The following is a description of a gene set: Genes containing one or more binding sites for (ZNF318) in their promoter regions (TSS -1000,+100 bp) as identified by GTRD version 20.06 ChIP-seq harmonization. Human Gene Set: ZNF318_TARGET_GENES from publication Yevshin I, Sharipov R, Kolmykov S, Kondrakhin Y, Kolpakov F (PMID 30445619) studied in species Homo sapiens, and this is the list of marker genes: TNFAIP8L1, MLH1, COG4, TXN, MX1, VAT1, GYPA, IRF2-DT, CAND1, TAP1, SEC13, TVP23B, MIR194-1, SIRT4, ANKRD24, EP400P1, STON2, DTX3, RPL15 (ribosomal protein L15), BTBD19, NRSN2-AS1, SEL1L3, APOOL, DUTP1, MAT2B (methionine adenosyltransferase 2 non-catalytic beta subunit), RPL7, DDX42, CTTN, FEM1A (fem-1 homolog A), RPS10, RNU2-2P, RPL4, ZNF280B, NOS3, USP36, ZNF432 (zinc finger protein 432), RNY3P11, APOL1, IQCG, MORF4L2, PLIN3, VWA8, CTNNA2, VMP1, ZBTB38, TFRC, LINC00649, ADARB1, NR1D2, AP1G1, ATP8A1-DT, RPL32, ENTPD6, EIF4G3, MIR3677HG, SNORD43, TNFRSF19 (TNF receptor superfamily member 19), ZFAND3, LARP1, TMEM116, LINC02608 (long intergenic non-protein coding RNA 2608), RPL36, FAM13A (family with sequence similarity 13 member A), PXN, PAQR3, SELENOKP2 (NCBI Gene Id 100127908), RNVU1-31, RFX5, GYPE, USP9X, NDUFA4L2, KCNH8, ENSG00000266401, KRTAP2-4, LINC03023, YPEL3, PSAP, NFKBIL1, SLC51A, CDK16, EPS15L1, ATF6-DT, SIX5, RNVU1-18, ENSG00000268129, ACOX2, RNU12, RNVU1-3, NOL8, HPS6, RFX2, THAP9, HMBS, KLHDC8B, LINC02953, RNU1-108P, TMEM259, PEX1, RPL7L1, LINC00299, RIMOC1, MTATP8P1, HNRNPUL1, ISY1, MTFR1L, LGALS1 (galectin 1), CYTOR, ATP8A2, BHLHE40-AS1, RPS3, ERP29, NBN, SLC35E2A, YWHAE, CP, APOBEC3C, ENSG00000255491, SNORD15A, GNL3L, LINC01275, GARNL3, RPL23AP81, PUM1, SNORA50C, ESAM, SNORD58A, LONRF1, EIF2S3, RPL17, SNORD118, ZSWIM8, CCDC150, EVL, PLAU, PPP1R9B, TNK2-AS1, RESF1, GBA1, ISG15, MDGA1, SMAP2, MRPS18B, HID1, GTF2A1-AS1 (GTF2A1 antisense RNA 1), TMEM144, DIPK1A, RPL26, LINC01132, RBM48, HEMK1, SKIDA1, ENSG00000246308, ACSM3, UBE2O, ERAP1, SAE1, CCDC42, MBD5, HES1, LCORL, LRBA, EEIG2, RNVU1-30, FOSB, CREB3L1, RNU2-17P, LINC00964, PCAT6, RBL1, ZCCHC24, SCARB1, TPP1, TRAPPC9, SYNGAP1, ADGRG3, APOL3, UBE2Q2P13 (NCBI Gene Id 100128108), CDK11B, BCL3, FRAT1, SEC31A, POLB, OSGIN1, RPL37A, TEPSIN, POLR2J3, RPS9, ALAS1, ISLR2, ALG1L13P, FABP5P5, SSBP2, GREB1, ENSG00000259118, C7orf50, LINC00944, RNVU1-28, HJURP, ERC1, RALGDS, GCDH, DZIP1L, ZDHHC20-IT1, ABHD12, LTBP1, SAMD4A, SPATA1, SRP72, GUSB, GOLGA3, TRIB3 (tribbles pseudokinase 3), RNU7-1, PNPLA1, TACC3, PARP14, RHOBTB3, ABCG1, NRG4, FOSL2, RPL7A, YBX3, CDA, AFG2B, GBE1, GDF11, CLIC4, PCID2, MYL6B-AS1, APOLD1, FAM83A, ZFPM2-AS1 (NCBI Gene Id 102723356), SCUBE1-AS1, C9orf72, SMG7, TM2D3, WDR36, SMG1P1, DAXX, WDR74, GDF15, DM1-AS, BRD7, SEC24C, STRIP1, FAM111A, ZFR2, ACIN1, FAM83G, TSR2, KAZN, ATF4, CCNG1, ENSG00000187951, MED22, IQGAP2, ENSG00000267174, NAT10, GABPB2, LAMTOR1, ZC3H7A, RNU2-63P, MRPL48, GTPBP2, FXYD2, TRIP6, TCAM1P, SLC6A6, SOCS1, CREM, IRF2, ATP1B3, RN7SKP91, SMARCA2, CDCA7, DSCR8, NFIX, TIMM17A, CASS4 (NCBI Gene Id 57091), HDAC6, DPH5-DT, CRPPA-AS1, RNVU1-27, LYN, CMSS1, RNVU1-2A, ST13, TPM4, FOXK2, SLC25A10, ANAPC10, IFI6, CD70, UBE2I, GET3, ERMARD, ANKRD1, SSC5D, RGS20, DSCR4, CCDC8, S100A2, TTC39A, TMEM18, AMOTL1, MED8, RAB7A, XXYLT1-AS2, TMSB4X, ENSG00000249713, LNCTSI, LINS1, PRELID1, SLC41A2, H4C8, AP2B1, WWC2-AS1, MOK, RAD52, MYH9, FCHO1, ZBED5-AS1, ID2, PSMB8, SLC26A8, ZNF335, ODC1, CDYL, TMBIM1, CRTAP, STAG2-AS1, LINC01300, STK40, ABCE1, NFIA, DNASE1L3, CEBPB-AS1, GABARAP, TRAJ7, CASC3, WRNIP1, OSER1, MEF2C, SNX29P2, H2AC6, TRIM2, TCF3, PLEKHA4, AHI1, TBL1X, FBXL9P, SNORD13, ATAD2, LNC-LBCS, THUMPD3-AS1, GRK2, ANXA11, MYEOV, ZNF138, TRIM25, RNVU1-34, DUSP16, RPL5, MYO18B, TUBB2A, COPZ1, GATAD2A, SP110, BHLHE40, FAM21FP, BRCA2, TFE3, BZW2, GNL1, RPS15, RNVU1-25, DNAJB2, RN7SKP168, PEAK1, CENPW, FCRLB, SLC7A8, ENSG00000253986, SLC13A3, BSG, PLA2G6, DUSP10, HOXC13, MAST2, NUP155, CCDC47, RPL37A-DT, RNU4-1, WDR76, ANXA2, MAF, IGF2BP3, MSLNL, PPP1R13L, PRR3, SYF2, RPL29P20, LINC01531, DHRS3, GLA, RPL36P10, DLX4, ANKUB1 (ankyrin repeat and ubiquitin domain containing 1), S100PBP, B3GNT8, IKBKG, CCN1, RPS18, SCFD2, PARP12, BRD2, NAPEPLD, USP49, CTH, MPV17, GP6-AS1, LINC02777, PABIR1, DDX39A, KIAA0319L, WDR45, RASA4CP, GCLM, SNRPE, FUT3, QPCTL, DDX39B, RPL38, ST7-AS1, ANKRD53, MED6, VIM, RNVU1-4, IL1R1, ZDHHC17, CCNG2, DNHD1, FAM184A (family with sequence similarity 184 member A), NCSTN, OSBP, SLC22A18, NSUN6, SNORA7A, THAP4, ZNF574, RPL35, LINC02980 (NCBI Gene Id 124906555), RPL23, AIG1, STAG2, RPS14, CTCFL, EHD1, ARHGAP1, ADAMTS6, LINC02652, KIF2A, KNL1 (kinetochore scaffold 1), EEF1A1, RPL29, RPL41, S100Z (S100 calcium binding protein Z), B3GAT3, ODC1-DT, PTCH1, SUGP2, PCBP1-AS1 (PCBP1 antisense RNA 1), KDM5C, MIR4757, RUFY3, JMJD1C, POLDIP3, C6orf52, BCAT1, SBNO2, ATP8A1, LINC01679, NMI, PPP1R15A, ATP2C1, RN7SL36P, FAH, RUNX1T1, RNVU1-21 (NCBI Gene Id 106480190), SETD7, HDDC2, SLC3A2, DEDD2, RBM3, GPI, KIAA0586, ATP6V1G2-DDX39B, CENPT, HNRNPH2, NIPA2, RERE, LINC00938, WDR1, ZFR, SREBF2, NR4A3, ENSG00000237813, MIR22HG, EIF6, PLCB1, HOMER1, DCTN6, MAU2, DDIT4, RPS3A, GCSAML, ITGB5, CD59, ABCC3, NDUFS3, CHMP3, CLCN3, SLC12A8, ZNF561, ATF7IP, GFI1B, MPDU1, YWHAQ, TUBGCP3, ING5, ISY1-RAB43, CASP8, CEP85, FTL, PCBP2, AXL, LINC01748, NFKBID, NKIRAS1, APOL2, COTL1, AKNAD1, NR4A1, LINC00887 (NCBI Gene Id 254808), RNA5S17, RNVU1-7, ENSG00000258623, ARAP3, FLT3LG, CFAP96, RHOT1, LINC00607, FAXDC2, POLR1G, ENSG00000235480, RPS24, ST7-OT4 (NCBI Gene Id 338069), PAXBP1, ALDH1A2, ZBTB21, ABHD2, BOLA2P1, PATL2, ZNF451, H4C4, WASHC2A, SEC22B, MTATP6P1, PPP4R1L, LINC00958, ARG2, FAM118A, MUS81, ZFAND3-DT, NFKBIE, GHRL, PCYOX1L, AVL9, MIR3189, MORF4L1, SLC48A1, WDR62, MORF4L2-AS1, CFAP20, FAM53C, AMMECR1L, THADA, RNU5A-1, FAM241B, CD163L1, TGIF1, ZNF561-AS1 (ZNF561 antisense RNA 1 (head to head)), RFX5-AS1, LINC00957, RNU5E-6P, COPA, SNORA21, SIAH1, LINC01719, LINC02100, TNFAIP3, ZEB2-AS1, RCOR1, TAGLN2, SPTA1, ADAR (adenosine deaminase RNA specific), GNGT1, IDS, SERTAD4, SP140L, DMWD, MIR5188, ENSG00000273727 (U1 spliceosomal RNA), CHD2, NKD2, TMEM132A, ABT1, POPDC2, ZNF841, BCL2, TNFRSF10B, TRIM11, OGT, UBC, LAPTM4B, PRR7, ADSS1, RPL17-C18orf32, ISG20 (NCBI Gene Id 3669), ADO, ITPR1, SNORD68, HJV, HTATSF1P2, ST7 (suppression of tumorigenicity 7), LGI4, ALKBH3-AS1 (NCBI Gene Id 100507300, ALKBH3 antisense RNA 1), TTI2, PARP10, LINC01366, ENSG00000189229, ZRANB2-DT, G6PC3, RPL10A, RPSAP28, CUX1, LAMP1, RNU5E-1, DMXL2, RNU5D-1, PDXK, VPS52, SHISA5, FAM186A, ZC3H4, KRT18, KLRK1-AS1, TSC1, KAT2B, EIF4ENIF1, FBXO8, ATP6V1G2, ZAR1L, SLC4A1AP, PLAAT5, RN7SL473P, ZNF669, STAT2, KDM3A, SLEAR, OSER1-DT, STAT1, NKIRAS2, BPHL, CYTH1 (NCBI Gene Id 9267), KICS2, ASIC4, IGFL2-AS1, RNVU1-26, POLR2M, ENSG00000227706, MSRB1, YARS1, ALDH5A1, CD164, CHPT1, TNS1, INO80, CLASP2, HIVEP3, RNVU1-15, NSMAF, REXO4, MPDU1-AS1, APOBEC3D, THAP8, DDX39B-AS1, MYL4, TRIM69, MTHFR, PTBP1, FHDC1, EIF2AK3-DT, MRPL1, PRDM10, BAIAP2, SARDH, ATF3, MBD6, ARL5B (ADP ribosylation factor like GTPase 5B), CLCN6, PPM1K, VPS54, ENSG00000268460, FLJ12825, C12orf57, MCL1, CD63, SUCLA2, ANP32E, SSR4P1, RNU6-2, ILF3, UNKL, DYNLT4, ZBED5, MED15, RNU4ATAC, LURAP1L-AS1, HMGB3P32, VAMP2, SPINK4, ILF3-DT, NAGLU, NRSN2, MIDN, RPL6, CSF2RA, NR2F6, RPL34, ARPC5L, ZNF292, BTN2A2, SNORD95, DDX18, PI16, PPP3CA, GADD45B, ZNF131, SF3B3, PPP1R10, RPS2P6 (NCBI Gene Id 342808), SZT2, RPS15A, DEDD (NCBI Gene Id 9191), FOXA1, KDM1B, MAGOHB, PATL1, TBC1D4, CHCHD2P1, SRRT, NUCB2, DYNLL2, LINC02000, RPAP1, MIR4435-1, SREBF1, CD27-AS1, RELN, TBC1D16, MIRLET7IHG, CLPTM1, CASK, ABCA15P, FBN3, GARRE1, MFAP4, TMEM208, TSC22D4, FBXL13, B2M (beta-2-microglobulin), TDH, SMARCE1, LINC01287, CYP1B1-AS1, ANKRD11 (ankyrin repeat domain containing 11), TM9SF4, NCDN, MIOS-DT, KNTC1, CREB5, TIMM9, GOLGB1, RNU7-124P, PPM1K-DT, SRSF3, MAN2A2 (NCBI Gene Id 55485), LSM5, MYB, CSRNP1, RNVU1-29, TMEM248, GYPB, FBXO45 (NCBI Gene Id 414772), NEDD4L, NHLRC2, ELSPBP1, DMAC2L, BCKDK, ACBD5, DPY19L3, PDE6G, FBLN2, MIDEAS, THAP9-AS1, TBC1D13, PRMT1, SNORD58B, LINC01418, SORBS1 (sorbin and SH3 domain containing 1), RENBP, ENO3, SLC45A4, USF2, GRPEL2-AS1, NFKB1, INO80C, ANAPC5, PAK1IP1, LINC00656, DYNLL2-DT, ENSG00000266976, SLC39A8, RNU5F-1, ADGRE5, HES4, TM4SF19-DYNLT2B, PIP4P1, RPL27, TENT5B, SEPTIN6, ZNF275, CMTM3, RPL37, DNAJC7 (DnaJ heat shock protein family (Hsp40) member C7), KLHDC9, BIN1, MEIS2, BAGE2, SLC9A1 (NCBI Gene Id 6548), EIF4E, TRPV2, ZNF408, RMC1, ITM2C, TRAPPC14, RPL11, RNU5E-4P, LEMD2, SNORD3J, DDX3X, ELOVL6, SUPT7L, GNLY, CLIC2 (chloride intracellular channel 2), SPRED2, MIR5087, PICALM, SOCS2, RRN3P3, TBC1D25, RSRC2, LINC02139, CTNND1, PRSS16, AKR1A1, BSG-AS1 (BSG antisense RNA 1), BCL6, RIMBP3, LINC01258, RPL34-DT, ATF6, KIF5C (kinesin family member 5C), LINC00475, SCIN, EIF4G2, LINC01610, RN7SL371P, RPL9, INHA, MAFK, MAP3K7, RSAD2, ABCB9, OTUD5, TNPO2, HSP90AB1, NEB, DUSP13B (dual specificity phosphatase 13B), PABIR3, LINC02870, PRECSIT, YTHDF2, LINC01270, SFT2D3, KLF6, TAPBPL, GNG5, OBSL1, CNOT6, CYTH4, ZDHHC6, NEAT1, KAT6B, IRF2BP2, SEPTIN8, NSUN4, DPY19L3-DT, PDE4A, NUB1, CHTOP, HCG20, SRXN1, ENSG00000187185, DCLRE1A, XPNPEP3 (NCBI Gene Id 63929), C9orf43, BRD4, PLK3, SRD5A3-AS1, CFLAR-AS1, TRIB1, MAPK6, ACP5, CCSER2, STAT6, TMEM18-DT, SLC23A1, CALM2, ZC3H12A, NOCT, EI24, BRWD1, HNRNPA0, TMEM140, RPL13, YPEL5, EFHB, NADK, ATF1, IFIT3, LAPTM4A-DT, MIR4734, BCRP6, ARL4A, ZBTB17, RNU4-2, WDR53, ENSG00000272008, BTN3A3, FCHSD2, CLASP1, ZNRF3, HNRNPR, RPA3, CTSB, TFAP4, IGF1R, EPM2AIP1, ENSG00000259182, MARCHF6, PIGM, CLDN7, ZEB2, NCK2, MCCC1, H4C2, RPL35A, RMI2, MIRLET7I, PROSER2-AS1, PGPEP1, CAMK2D, SNX8, RNVU1-19, RPS7, CYREN, TBKBP1, ZNF232-AS1, ZNF300, SNORD104, OGDH, RNFT2, RPS10-NUDT3, RPS26, EIF2AK3, SNORD84, ARHGEF2, ARHGEF2-AS1, ENSG00000240687, KLKP1, RACK1 (receptor for activated C kinase 1), BACH1, WDR43, RAB30, SMG7-AS1, MIR3681HG, SNHG25, BATF2, MICALL1, FAM21EP, RNU11, ATG3, RNVU1-14, MDC1, SQSTM1, GP6, LINC02928, KLK1 (kallikrein 1), STX4, CCT7, CA5AP1, E2F3, ERO1A, EMP3, CLK1, SLC7A11, ZCCHC2, LINGO1, ENSG00000221040, KRBA1, AQP10, CELA2A, NAPA, MLLT10, SMIM20, RPL3, LAPTM4A, PARN, RN7SKP245, TMEM87B, FAM111A-DT, MCPH1-AS1, UBXN6, NBEAL1, ADGRL1, PER1 (period circadian regulator 1), MFAP3L, HLA-DMA, TM4SF19, CSF3R, DNPEP, ZNF417, MCM5, AMPD2, PTPA, H6PD, SLC2A1, KIFC3, NFE2L2, EEF1G, KRT8, NUS1, VTI1A, NPIPB2, HOXB9, ALKBH7, CLIP1, ORC4, RNVU1-2, WASHC2C, OAS3, ZRANB2, RPL18P10, FEM1C, EPCIP-AS1, RMDN3, RNPS1, HIF1A, HMG20A, SLC1A5, ZNF616, PDE4DIPP6, CDK12, SNRPB, GYS1, NECAP1, CLN8 (CLN8 transmembrane ER and ERGIC protein), TMSB10, RNU5B-1, KMT2D, CLEC2B, CCNI, IL15RA, CSNK1D, TCP11L2 (NCBI Gene Id 255394), ZNF510, NAGK (N-acetylglucosamine kinase), CDK5, GTF2A1, TRMT1, HK1, XPO6, PKM, CFL1, DAPP1, KCNH2, ZNF280C (zinc finger protein 280C), IFIT5, PSMB9, ANAPC16, RFC2, POLE3, RNU4-38P, SLC35A5, LINC00431, KRT17, PDGFB, PCK1, PC, RASGRP3 (RAS guanyl releasing protein 3), LRRC41, CTTNBP2, MSANTD3, EHBP1, TMEM260, DENND4A, PSMB8-AS1, RPS6, MTMR4, ENAH, C2orf68 (NCBI Gene Id 388969), LZTS2, KBTBD4, PACSIN2, RNVU1-22, LIAS, NNMT, NFE4, ENSG00000266313 (NCBI Gene Id 124903957), UFSP2, ZWILCH, LINC02773, MIR548AW, LINC01353, SLC38A1, BCAN-AS2, EPOR, LY6K, TNRC6C, CENPP, ARID5A, RNVU1-6, CDC42SE1, CARD10, HPGDS, TRA2B, CALB1, RCAN1 (NCBI Gene Id 1827), DHRSX, CEP44, IKZF4, RPL31, CALCOCO2, DNPEP-AS1, U2SURP